Given this list of marker genes RAC1, FYN, PLCG1, NRAS (NCBI Gene Id 4893), GRB2, CDK5, CDK5R1, GAB1, BDNF, HRAS, PIK3R1, PIK3CA, TIAM1, FRS2, GRIN2B, PTPN11, NTF4, SOS1, FRS3, SRC, NTRK2, KRAS, NTF3, DOCK3, SHC1, here is a description of the gene set: Signaling by NTRK2 (TRKB) species: Homo sapiens Human Gene Set: REACTOME_SIGNALING_BY_NTRK2_TRKB